Given this list of marker genes PRKACB, PAK6, CLASP2, RPS17, RPS2, RPL22L1, SLIT3 (NCBI Gene Id 6586), SRGAP3, RPL38, RPL34, MYO9B, MSI1, RPS15A, FAU, PAK1 (p21 (RAC1) activated kinase 1), RPS4Y1, RPL27, UPF3A, RPS9, PFN2, CAP2, RPL24, RPS19, ROBO2, RPL8, PSMD13, PSMC2, PSMD7, ELOB, CUL2, RPL5, RPS6, CXCL12, RPL7, PRKACA, RPS4Y2, ARHGAP39, RNPS1, SOS1, PSMD8, CASC3, LDB1, RPL11, PSMB1, NELL2, SLIT1, NCBP1, PSMD1, RPL13, RPL6, PSMB5, PSMA6 (NCBI Gene Id 87553), SRGAP1, RBX1, RPS23, ABL2, RPL3L, DCC, RPS25, MAGOHB, RPS29, RPS20, RPL7A, LHX9, PSMA7, LHX3, FLRT3, PSMA2, PSMC1, PAK3, RPL36, RPS27A, RPL35A, RHOA, MAGOH, RPS18, RPL10L, LHX4, CAP1, NCBP2, USP33, PSMB2 (proteasome 20S subunit beta 2), LHX2, RPS27, RPLP0, RPS16, RPL19, ISL1, PSMC6, RPS24, RPL26, UPF3B, ABL1, RPLP2, DAG1, RPL10A, SEM1, NCK1, RPL9, AKAP5, UBC, GPC1, RPS13, ENAH, NTN1, RPL36AL, RPL39, CLASP1, RPL36A, ADRM1, ZSWIM8, RPL28, RPS28, RPL31, EIF4A3, RPS11, RPS7, PSMD3, SOS2, RPL4, RPL29, COL4A5, PSMB3, RPS27L, PSMD14, SRGAP2, PSMD11, PSMD6, RPS26, PSMC5, UPF2, RPL3, RPL41, PPP3CB, RPSA, RPL21, PRKCA, NRP1, RPL12, RPL23A (NCBI Gene Id 6147), PSMA1, PAK4, SLIT2, GSPT2, RAC1, RPL10, RPS3A, RPL35 (NCBI Gene Id 92393), RPL26L1, RPL39L, PSMB4, RPL14, PSMC3, UBB, PSMB6, RPL37A (ribosomal protein L37a), RPS15, RPS8, PAK2 (NCBI Gene Id 9106), RBM8A, PRKAR2A, EVL, CXCR4, RPL30, PSMA5, EIF4G1, RPS12, ETF1, RPL13A, VASP, RPS14, PABPC1, RPL22, SRC, ROBO1, RPL18A, RPS3, PSMA4, RPS21, NCK2, RPL32, RPL23, PSMA3, PSMC4, RPL17, PRKACG, PFN1, UBA52, PAK5, RPL18, ROBO3, RPL15, PSMB7, ELOC, PSMD12, CDC42, RPL37, RPS5, RPLP1, HOXA2, RPL27A, PSMD2, RPS10, RPS4X, GSPT1, here is a description of the gene set: Human Gene Set: REACTOME_SIGNALING_BY_ROBO_RECEPTORS studied in species Homo sapiens Signaling by ROBO receptors